The following is a description of a gene set: Human Gene Set: REACTOME_RUNX2_REGULATES_OSTEOBLAST_DIFFERENTIATION RUNX2 regulates osteoblast differentiation species: Homo sapiens, and this is the list of marker genes: RUNX2, WWTR1, HEY1, SATB2, HEY2, ABL1, MAPK1, HDAC6 (histone deacetylase 6), SP7, UCMA, YAP1, MAPK3, HES1, GLI3, YES1, SRC, RB1, COL1A1, CBFB, HDAC3, ZNF521, BGLAP, MAF, AR